The following is a description of a gene set: studied in species Homo sapiens Human Gene Set: chr13q11, and this is the list of marker genes: LINC00328-2P, LINC00388, TERF1P5, LINC00349, SNX19P2, IGSF3P1, KMT5AP1, BNIP3P7, ENSG00000276183, LONRF2P2, CNN2P12, RNU6-55P, RNU6-76P, RHOT1P3, FAM230C, CYP4F34P, LINC00387, ANKRD20A9P, GGT4P, FEM1AP4, SNX18P26, GXYLT1P1, FAM207BP, ZNF962P, ZNF965P